The following is a description of a gene set: studied in species Mus musculus Mouse Gene Set: GOMF_HISTONE_H3K27ME2_H3K27ME3_DEMETHYLASE_ACTIVITY Catalysis of the removal of a methyl group from a tri- or a dimethyl-lysine residue at position 27 of the histone H3 protein. This is a dioxygenase reaction that is dependent on Fe(II) and 2-oxoglutarate., and this is the list of marker genes: Uty, Kdm6a, Phf8 (PHD finger protein 8), Kdm7a, Kdm6b